The following is a description of a gene set: Binding to a member of the importin-alpha family. Human Gene Set: GOMF_IMPORTIN_ALPHA_FAMILY_PROTEIN_BINDING studied in species Homo sapiens, and this is the list of marker genes: GOLGA2, RB1, KPNB1 (karyopherin subunit beta 1), CDADC1, DHX9, EI24, DESI1, RAN, TPX2